The following is a description of a gene set: An abnormally increased number of mitochondria in the cytoplasma adjacent to the sarcolemma (muscle cell membrane), whereby the mitochondria also possess an abnormal morphology. Subsarcolemmal accumulations of abnormally shaped mitochondria species: Homo sapiens Human Gene Set: HP_SUBSARCOLEMMAL_ACCUMULATIONS_OF_ABNORMALLY_SHAPED_MITOCHONDRIA, and this is the list of marker genes: SLC25A4, TWNK, PNPT1, TYMP, ISCU, POLG